Given this list of marker genes MAP3K5 (mitogen-activated protein kinase kinase kinase 5), MAPK9, MAPK10, MAPK8, TXN, here is a description of the gene set: Pathway Definition from KEGG: PQ -> ROS -| TRX1 -| ASK1 -> JNK Human Gene Set: KEGG_MEDICUS_ENV_FACTOR_PARAQUAT_TO_FAS_JNK_SIGNALING_PATHWAY Paraquat to FAS-JNK signaling pathway. Pathway ID: N01417. Pathway type: Env factor. Pathway class: nt06463 Parkinson disease. species: Homo sapiens